The following is a description of a gene set: from publication Yevshin I, Sharipov R, Kolmykov S, Kondrakhin Y, Kolpakov F (PMID 30445619) Genes containing one or more binding sites for (Hnf4g) in their promoter regions (TSS -1000,+100 bp) as identified by GTRD version 20.06 ChIP-seq harmonization. Mouse Gene Set: HNF4G_TARGET_GENES species: Mus musculus, and this is the list of marker genes: Ggcx, 2610005L07Rik, A330032B11Rik, Slc35c2, Dnajc25, Prickle4, Acot4, Ccnyl1, Sardh, Cldn7, Socs2, Ambra1, Gm11696, Wapl, Mgam, 2010003K11Rik, Fv1, Tpi1, Btnl2, Slc25a5, Tkfc, Slc38a6, Kyat1, N4bp2, Ngef, Acot8 (NCBI Gene Id 170789), Gsdme, Sdc1, Dhcr7, Trappc9, Atp5mc3, Zfp956, Emp1, 1700018L02Rik (RIKEN cDNA 1700018L02 gene), Pak1ip1, Gm829, Acadm, Cnpy1, Gm9484, Cct4, Xkr5, Ylpm1, Fam47e, Tm4sf20, Tldc2, Pgrmc1, Naxd, Usp5, Tmcc3, Ubash3b, Arhgef16, Ddost, Scrn2, Crebzf (NCBI Gene Id 70721), H4c8, Hgfac, Add1, Tcf25 (NCBI Gene Id 72298), Eif5, Iyd, Spdye4b, Epha2, Atg4d, Slc1a4, Slc30a1 (solute carrier family 30 (zinc transporter), member 1), Cyp2s1, Ap1ar, Itsn1, Dnase1, Gm38250, Sesn1, Pigl, Nhsl3, Nisch, Cldn2, Eif4h, Zmat1, Odad3, Eaf2, Reno1, Mir7240 (NCBI Gene Id 102466823), Sec22c, Zbtb40, Mkln1, Ist1, Gm3948, Eef1b2, Atp6v0d1, Pde8b, Zyx, Mirlet7c-2, Mad2l2, 4930511M06Rik, Slc2a7 (solute carrier family 2 (facilitated glucose transporter), member 7), Cript, Vil1 (NCBI Gene Id 22349), Plscr2, Vcpip1, Cideb, Cxcl11, Ints10, Rgs3, Osr2, Gm11844, Ckmt2, Bach2, Trafd1, Map2k4, Bri3 (NCBI Gene Id 55950), Celsr3, Pyroxd1, Atp6v1a, Pank2, Tcn2, Nfyc, Ptpn3, Aftph, 1700021P04Rik (NCBI Gene Id 75521), Dpf2, Asah2, Pm20d1, Epg5, Trim7, Epn1, C230037L18Rik, Acsl1, Rcor3, Paxbp1, Sgk3, Patj, Cyp24a1, Smarcc1, Xpnpep2 (NCBI Gene Id 338497), Mitd1, Gipc2, Acp5, Pxylp1, H2-T5, Alkbh3, Arsg, Sel1l3, Foxk2, Sbf1, Efnb1, Il4ra, Zfp1, Rcc1, Rhpn1, Rbl1, Farp2, Alas1, Mep1b, Lrp4, Gramd1b, Cnst (consortin, connexin sorting protein), Sec16a, Pcmtd1, Abhd14a, Lif, Enox2, Nop58, Btnl5-ps, B930036N10Rik, Dnm1, Tcf3, Slc23a2, Tpcn1, Carhsp1, Trpm5, Fgf9, Gm15901, Hic2, Naa50, Ppp1r16a, Gm4755, Ccnl1, Pdzk1, Cyp4f14, Cramp1, Lmo7, C2, Gne, Gm15401, Cenpv, Dcdc5, Ifngr1, Mrpl33, Dusp12, Pafah2, Gltpd2, Gm7285, Sqor, Pms2 (NCBI Gene Id 18861), Gpsm2, Rock2, 2810405F17Rik, Pla2g2e, Hmgcs1, Pfkp, Inpp4a, Pabpc4, Cep57l1, Ogt, Polr2b, Aunip (NCBI Gene Id 69885), Sra1 (NCBI Gene Id 24068), Prag1, Tm6sf2 (transmembrane 6 superfamily member 2), Akt2, Bid, Alpi, Slc5a9, Pbld2, Arf4, Hdgfl2, Lctl, Mcm10, Gm16984, Elk4, Tob2, B230206L02Rik, Dglucy, Slfn2, Tyw5, Tpcn2, Ucp2, Bmp2k, Nt5c, Relch, Acot12, Ddr1, Eogt, Gm12188, Pex11g, Sepsecs, Gsk3a, Hdhd3, Gm15938 (NCBI Gene Id 105245873), Gm13588, Plekhs1, Tbcd, Erg28, Elf4, Nkap, Zhx2, Arrdc4, Pde11a, Gcc1, Ccs, Gm9945, Tmem236, Arl1, Gm15587, Sptlc1, Cacul1, Tom1l1, Eif1a, Cimap2, Sult1b1, Tmem147, Eif4b, Gm23054, Gm14050, Inafm1, Fam110c, Cfap61, Tbc1d1, Tnpo3, Bloc1s2, 1700001L05Rik, Prrx1, 2010010A06Rik, Ten1, Rps27l, Lgalsl, Sgpl1, Tap2 (transporter 2, ATP-binding cassette, sub-family B (MDR/TAP)), Rest, Ankrd9, Miip, Bmf, Kyat3, Cdhr5, Hycc1, Arcn1, Atp5f1b, Gnl2, Erich4, Nr2f6, Ift140, Tmem120a, Mrpl44, Cflar, 2310030G06Rik, Hpdl, Idua, Slc9a2, Adprm, Ccser2, Nqo2, Flacc1, Tnfaip8l2, Ldlrad3 (NCBI Gene Id 98873), Kmt2c, Irf1, 1810013D15Rik, Lmbrd1, 6030442K20Rik, Gm13963, Kif15, Irf2bp2, Dnajb11, Adcy3, Oser1, Nckap5, Irf9, Krtap3-1, 4930443O20Rik, Cttnbp2, Cct8, Traj57, Rnps1, Efna1, Dhrs1, Chd2, Pih1d1, Cpeb2, Gm4651, Herc3, Gm11457, Enpp7, Myl4, Ebpl, Cbl, Tsg101, Jade1, Itga9, Arhgef18, Ccdc50, Tmigd1, Arfgef1, Rprd1b, Dctn5, Eif3f, Ifnl3, Ankrd13c, Ap1m1, Eif2ak2 (NCBI Gene Id 76759), Slc6a8 (NCBI Gene Id 12911), Zfp36l2, Tlcd4, Slc26a6, Bcr, Wdcp, Ncoa4, Tmc6, Cerk (ceramide kinase), Ces2c, Slc51a, H2-Q4, 2200002D01Rik, Pls1, Slc5a8, Mir3079, Nfil3, Psma4, Agxt2, Nup54, Pkn2, Fbxo22, Parp11, Tmem150b, Map3k10, Mmp24, Tbcel, Mgat3, Cdc42ep5, Aars2, Gm8849, Ces2a, Ift46, Wfs1, Gm4925, Cyp3a11, Pigm (NCBI Gene Id 98637), Pinlyp, C8g, Slc3a1, Cdk5rap1, Maoa, Ube2f, Gnai2, Actr2, Or52h9, Cpd, Ank3, Ptpn6, Phf7, Litaf, Aloxe3, Mir378a, Prr3, Irgm2, Chrna2, Ski, Lpin3, Arhgap27 (Rho GTPase activating protein 27), Slc10a5, Slc5a12, Gdi2, Aimp1, Ggt6, Mlycd, Rusf1, Slc7a15, Tnfaip3, Cant1, D5Ertd579e (DNA segment, Chr 5, ERATO Doi 579, expressed), Zbtb33, Lrrc66, Tulp4, Igsf23 (immunoglobulin superfamily, member 23), Tfrc, Ap5s1, Gm22018, Mir8116, Tmem51, Acbd4, Seh1l, Dck, Ifi27l2b, Nr1h3 (NCBI Gene Id 99182), Tmem106a, G6pc1, Usp3 (ubiquitin specific peptidase 3), Ganc, Kcnj8, 2310057M21Rik, Snai3, Klhdc8b, Mir8106, Zfp865 (NCBI Gene Id 319748), Junos, Dcp1a, Abcb4, Treh, Mrpl40 (NCBI Gene Id 18100), Camk2d, Ogfod3, Ccnk (cyclin K), Rsbn1l, Gm25857, Neu2, Gm28035, Ttll5, Cth, Slc35b1, Mrpl32, Rxra, Cfap74, Ormdl1, Mab21l4, Hes6, Snrpc, Ces3b, Sgk1, Gramd2a, Gm8813, Ppp1r14d, Apob, Itpka, Fbp2, Dcst1, Smad7, Aspdh, Ints8, 5031439G07Rik (RIKEN cDNA 5031439G07 gene), Tmem143, Spink1, Crip1, Mep1a, 4833439L19Rik, Brd10, Btf3l4, Pcnx3, BC016579, Naga, Klf4, Angptl8, Cyp3a13, H2-T9, Mst1r, Tnk1, Fcho2, Pxn, Dop1b, Myo1a, Kbtbd11, Rdh5, Slc30a2, Specc1l, Cdkl1, Hnf1aos1, Sh3gl2, Taok3, Crat, 6530401F13Rik, Maf, Apoc2, Kdm6b, Rmi1, Gm11468, Tnfrsf1a, Grtp1, Stoml1, Adtrp, Ablim1, Chac2, Il11ra1, Rad9b, Snx20, Rps5, Tmem253, Mapk1ip1l, Rdh16f2, Rcbtb1, Rsrp1 (NCBI Gene Id 72409), Prpf4, Gtf3a, Ssbp2, Macir, Gm12915, Rapgef1, Arfip1, Prpf18, Ecd, Lims1, Ankrd37, Traj3, Fhip1b, Ino80c, Abhd16a, Kiss1, Cyp4b1, Rassf1, Cds2, Tmem86b, Kdm3a, Mkrn1, Gm22310, Gm4285, Kmt5a, Elovl6, Tpd52, Sf1, Vcpkmt, Cnksr1, Zfp706, Slc7a7, Rhobtb1, Foxp1, Apba3, Srsf2, Abhd14b, Frrs1, Zfp110, H2-Q1, Uso1, Mpz, Babam2 (NCBI Gene Id 77716), Mtbp, Ndufab1, Ptbp3, Stx16 (NCBI Gene Id 99409), D630024D03Rik, Mir5615-2, Ifi27, B230354K17Rik, Jak1, 1810008I18Rik, Sertad2, Dtx4, Txndc12, Bok, Mrpl1, Pou6f1, Akap10, Ubap2l, Ptpmt1, Dgkq, Nudt19, Cd160, Itih5, Mfn1, 4833420G17Rik, Gnl1, Rbm48, Gm16982, Fhl2, Cyp2b10, Igtp, A230107N01Rik, Ndufs6, Spen, Selenop, Mtarc2, Pik3r2, Rab11b, Gm16191, Cyp2c65, Mtrf1l, Tjap1, 9330175E14Rik, Fuom, Cenpa, Ggn, Gm12610, Rnasel, 1810019D21Rik, Rbm4b, Gm16096, Crybg2, Chchd7, Myo7a, Dnaaf5, Nek2, Cdk16, Rbm47, Hyal2, Nosip, Rwdd2b, Sf3a2, Cdc26, Aen, Chd1, Mical2, Vps26c, Gm17135, 4933434E20Rik, Gm22847, Snap23, Pstpip2, Bend7, Pklr, Mov10, Lrrc8b, Timm13, Rpl22, Mrpl35 (mitochondrial ribosomal protein L35), Acat3, Chp1, Chst8, Nrap (NCBI Gene Id 18175), Ttc27, Ptpre, 4930442L01Rik, Sgms1, Zfp93, A230083G16Rik, Rbak, Otulin, 1110059G10Rik, Synpo2l, Aqp1, Ciapin1, Mkks, Rab11a, Med6, Lyz1, Irak2, Ppdpf, Smu1, 6030445D17Rik, D2hgdh, Dnajc24, Mme, Mir1934, Ube3a, Traj56, Sema6a, Decr1, Rgs12 (NCBI Gene Id 77052), Pmf1, Slc2a5, Mafg, Nudt12, Rnf7, Entpd8, Tmem38a, Ctnna1, Myrfl, Mapre2, Tprn, Sult2b1 (NCBI Gene Id 545963), Cers6, Sdhc, Syne2, Prap1, Atp6v1e1 (NCBI Gene Id 76771), Pstk, Lpar1, Maip1, Nadsyn1, Pttg1ip, Gins3, Gm10244, Ubqln1, Resf1, Ankrd40cl, Rnf128, Erc1, Pgm1, Ppt2, Sec16b, Gm12220, Tiprl, Spata13, Mtarc1, Ece1, Copa, Zfp69, Il13ra1, Lztr1, Foxk1, Dclre1a, Cep170b, 4632415L05Rik, Ccdc57, Slc25a25, Nek3, Tgfbi, Slc36a1, Cers2, Spats2l, Gm11586 (NCBI Gene Id 105243487), Gm35066, Lpcat3, Wasf2, Ccdc87, Cd81, Fut7, Wdr44, Gapvd1, Syngr4, Prrg2, Abcg5, Nbeal2, Plin2, Rpl7, Ppme1, H2-K2, Gmip, Tmem177, Zfpm1, Gin1, Inpp5a, Mir6909, Pou2af2, Ulk2, Ganab, Gata4, Cpsf1, Fmn1, Imp3 (IMP3, U3 small nucleolar ribonucleoprotein), Slc2a9, Gm23664, Top1, Golt1a, 2310016D23Rik, Snx1, Lrrc27, Guca2b, Fgd6, Fcsk, B130034C11Rik, Mapk8, Prpf40a, Ltbr, Bcat2, Setd3, Edf1, Frs3, H2-Q3, Hus1, Ctns, Cd9, Hdac11, Nostrin, Tti1 (NCBI Gene Id 98972), Gucd1, Pcnx1, Rad51, Rassf7, Med16, Cenpu, Zc3h6 (NCBI Gene Id 99301), Rogdi (rogdi homolog), Arl6ip6, Tbc1d14, Nr1i2, Cisd3, Cdc37l1, Gm11545, H2-Q2, Rasl2-9, Rbbp5, Lman1, Wdfy1, Trmt5, Ercc6, Unc93a2, Proc, Ppp1r18, Mtmr7, Mir203, Net1, Gm13250, 4933433G15Rik, Hadh, Neurl2, Uap1l1, Plscr3, Abat, Golim4, Gabarapl1, Rbks, Ube2i, Pkp4, Anxa4, Pabpn1, A1cf, Cab39, Mir7036b, Slc35a4, Slc41a2, Arsa, Gm13203, Aldh9a1, Phf10, Ran, Ilrun, Acy1, Alg14, Rab20, Washc4, Etfbkmt, Ihh, Akr1c14, Ccdc126, Dsg2, Gm42918, Cyp4f16 (NCBI Gene Id 70101), Xdh, Trp53rkb, Cox16, Gtf3c2, Strap, Rab43, Flot1, Rmdn3, Arhgef26, Clrn3, Sco1, Acox2, Mtmr4, Gba2, N4bp2l2, Gm14441, Stxbp2, Gm12602, Qars1, Gstm3, Rras2, Gm14167, Atat1, Pigg, Taco1, Rffl, Brip1os, Tbccd1, Tdrd3, Sf3b6, Ggnbp2, Slc47a1, Mir6349, Ino80, 2610021A01Rik, Gchfr, Gpt, Rars2, Strn, Susd2, Plpp1, Slc6a19, Mycbp2, 2900093K20Rik, Lamtor2, Fam3b, Smt3h2-ps2, Esrp2, Aoc1, Gm38388 (NCBI Gene Id 105243936), Slc43a2, Hectd2, Atp6v0a1, Nags, Ampd2, Cyp2c55, Ppp1r18os, Ptprh (NCBI Gene Id 545902), Tchp, Ctsa, Amn, Epb42, Spred3, Ndufaf4, Glyctk, Zdhhc12, Xrcc1, Stx3, Tmem87a, Hcn1, Ap2b1, Susd3, Sucla2, Slc25a14 (solute carrier family 25 (mitochondrial carrier, brain), member 14), Dgcr6, Mrpl34, Dnajc22, Rpl15, Rnf11, Gm5656, Wee1, Pafah1b3, Tmem37, Mapkapk2, Gm20619, Oga, G630022F23Rik, Rnd2, Brpf3, Ptbp1, Dtx3l, Tkt, Mpzl2, Mapk9, Cdk5, Ttk, Tg, Tnfsf10, Cox7a1, Gtf2e1, Stub1, Rmnd1, Rad54b, Zfp784, Hectd1, Pold2, Paip2 (NCBI Gene Id 67869), Tpt1, Ptprd, Adap1, Gnpda1, Pdia5, Bco1, Slain2, Uqcc6, Mir1932, Hmgcr, Tmc4, Cd47, Ttc33, Gm10658, Slc5a11, Elmo2, Raf1, H2-T15, Mettl27, Plekhj1 (pleckstrin homology domain containing, family J member 1), Bsdc1, 4933404O12Rik, Spg7, Zbtb7b, Lgals4, Atg5, Palb2, Gimd1, E030042O20Rik, Spaca7b, Tmem184a, Btf3, 9130019P16Rik, Gm11945, Adgrg7 (NCBI Gene Id 239853), Amfr, Bms1, F3, Gpr107, Gadd45a, Mfsd4b3-ps, Lgals2, Scpep1, Dmac1, Bst1, Rarg, Anp32a, Timm17a, Crnkl1, Gpa33, Gstm4, Dnaja2, Card14, Abhd15, Zfp872, Il17rb, Trim28, Cdc5l, Ice2, Zfp112, Pts, Alkbh7, Rps3a1, Mesd, Med27, Ifih1, Rab30, Hpgd, Rbm34, Vapa, Glt28d2, Sgpp2, Kmo, Mcfd2, Midn, Gm11527, Mlxipl (MLX interacting protein-like), Slc5a4b, Fryl, Cand1, Dgat1, Zbtb11os1, Leng9, Phgr1, Dao, Efcab7, Sec61a2, Slc16a3, Pnrc2, Ube4a, AY074887 (NCBI Gene Id 246735), Gm4189, Plag1, Zfp830, Mdh1b, Nop9, Mettl17, Tmc5, Ms4a10, Ssu72, Rnf121, Mycbpap, Ccdc97, Dlat, Gm12500, Tapbp, Spns2 (NCBI Gene Id 216892), Unc93a, Ecpas, Polr2a, Mir194-2, Fdxr, Wdtc1, Aldh16a1, Gm9409, Crb3, Fmo4, Apoc3, Src, Npas2, Commd2, Tmem165, Mttp, Has2os, Gm14383, Sun3, Nuf2 (NCBI Gene Id 98608), Gde1, Neurl4, Rab40b, Mir3968, Cntn2, Capn8, Tepsin, Cox19, 4632427E13Rik, Baiap2l2, Slc5a6, Gm7854, Doc2g, Sec24a, Gm14966, Nfe2l2, Furin, Clec2e, Pex11b (peroxisomal biogenesis factor 11 beta), Birc3, Otc, Mir429, Hdac4, Itgb5 (integrin beta 5), 2310005A03Rik, Man2b2, Abr, Rcc1l, Pex1, Gramd1c, Clcc1, Btbd2, Cast, Gm11335, Mdh1, Ndel1, Mtfr1l, Itgb4, Rab17, Alg11, Fbxw9 (NCBI Gene Id 68628), Wdr11, Ccdc71, Cfb, Dnajc28, Prkca, Hnrnpc, Taco1os, Cdcp1, Nyap1, Cyb561d2, 4833407H14Rik, Brip1, Cd302, Il22ra1, Asic3, Slc18b1, Slc5a1, 9130230L23Rik (NCBI Gene Id 231253), Bmal1, Erbb2, Slc16a1, Oma1, Rbm15, Ik (IK cytokine, NCBI Gene Id 24010), Golgb1, Gapdh, Ifit3b, Eif4g1, Mrps18b, Nat8f2, Tmbim6, Ralgds, Emc9, Rgp1, Abcd3, Tnnt1, Cct6b, Txn2, Tmem82, Nos1ap, Cct3, Mia2, Bnip3, Armt1, Smim15, 9430060I03Rik, Abcc3, Mir192, Rdh7, Carm1, Cit (citron), Pold3, Mfsd11, Ppie, Scp2, Ddit3, Selenoi (selenoprotein I), B3gnt2, Mgst2, 2810408A11Rik, Chdh, Otud7b, Cdhr2, Clec2h, Edn3, Azin1, Wipf3, Zfp354a, Ttn, Btnl6, Dkk4, Rasl10b, Tcf12, Dcaf10, Prkar1b, Hnf1a, Nlrc4, Podn, Eci3, Smarcd2, Nr1i3, Psma2, Senp1, Tuft1, Hes1, Eva1c, Zkscan1, Gm5475 (predicted gene 5475), Zfp696, Vps26a, Megf11, Itpripl2, Slc4a2 (NCBI Gene Id 20535), Fas, Upp1, Plec, Cspg4, Apbb1, 9930014A18Rik, Stx4a, Rdh9, Fastkd2, Ncor1, Mkln1os, Herpud1, Cpox, Ggt1, Gm42814, Anks4b, Ppp1r10, Prss30, Tmem238l, Stxbp6, Myo15b (myosin XVB), Hnf1b, Ptpa, Ctcflos, Rnf103, Osbpl6, Tcf7, Bpnt1, Fam107b, Prxl2a, Gm12059, Gm21049, 2610528J11Rik, Mtmr11, Smim7, Nrxn2 (neurexin II), Ppp4r3a, Grb7, Nckap1, Brwd1, Dennd6a (NCBI Gene Id 211922), Baat, Entpd5 (ectonucleoside triphosphate diphosphohydrolase 5), B3gnt3, Gpr35, Pdgfc, Chmp6, Slc28a1, Ms4a8a, Hacd2, Dnajc13, 2010308F09Rik, Stk24, Tmc8, 4930562C15Rik, Tjp1, Hivep1, Selenbp1, Tap1, Gm19391, Ptms, Slc9a3, Gm4349, Nfia, Pax6 (paired box 6), Qdpr, Cdc27, 4931413K12Rik, Eef2, Cyp27a1, Casz1, Gm17089, Tuba1c, Snora24, Gm13580, Cul4a, Gal3st1, Gas2, Cry2, AI507597, Abhd2, Gm11451, Slc35a3, Mrpl30, Psmd3, Mtif2, Lysmd4, Bud13 (NCBI Gene Id 215051), Chka, Isx, Cyb561, Fos, Pag1, Snhg8, Gzf1, Ppif, Fkbp1a, Slx4ip, Gas2l1, Spmip4, Islr2, Atpaf2, Gm15889, Sde2, Zbtb7a, Gsn, Arc, Ifnar1, Nabp2, Ctso, Myo7b, Perp, Slco2a1, Cyp2c29, Odad1, Pms1, Fam98c, Ube2c, Trmt61b, Trabd2b, BC004004, Bcl2l15, Nr1d2, Zfp948, Lrp3, Fbxw5, Fam53b, Nherf4, Fam169b, Csnk1d, 5730480H06Rik, Baz2a, Ceacam18, Ppp5c, Bco2, Gm15941, Gm10010, Zcchc8, Sec14l1, Tcerg1, Creb3l2, Prkcsh, Zfp292, Eps15, Orc3, Chmp2b, Hspa13, Gm29609, Pxdc1, C2cd3, Mpdu1, Gtpbp8, Nprl2, Proz, Sphk1, Mapk6, Zfp607b, Coro1c, Serpine1, Sectm1b, Tm4sf5, Spata1, Slc5a4a, Plscr1l1, Gm15417, Acad9, Nme9, A830005F24Rik, Abhd1, Ncaph2, Gga1, Dcxr, Rbp2, Park7, Hexim2, B4galnt2, Preb, Sema4a, C1rl, Sin3a, Zfp827, Cep89, Itga1, Eny2, Smim27, Plk5, Lypla1, Rad54l2, Oxr1, Fgd4, Cblc (NCBI Gene Id 80794), Zfp92, Scmh1, Gm26397, Rragc, Mroh7, Dsc2, Saxo2, Agrn, Nedd1, Efhd1, Gm4929, Mir1936 (NCBI Gene Id 100316812), Msh3, Arb2a, Ankrd54, 5430435K18Rik, Nup133, Tmem101, Espn, Ctif, Atg2a, 1700084C06Rik, Ap3m1, 4931406C07Rik, Cldn15, Sp1, Hsd17b13, Matr3-ps2, Pdcd11, Aqp8 (aquaporin 8), Aldh3b1, Mir7214, Blmh, Kalrn, Plekha7, Tmem139, Cldn3 (NCBI Gene Id 12739), Gm9917, Gm11544, Gp6, Nmi, Khdrbs1, Zfp286os (zinc finger protein 286, opposite strand), Mob3c, Ap1g1, Hook2, Tmem117, Lpp, Borcs6, Mllt11 (myeloid/lymphoid or mixed-lineage leukemia; translocated to, 11), Mir3103, Gng5, Rufy1, Traj4, 5330413P13Rik, Dusp23, Naprt, Tec, Trmt44, Gm14097, Pck1, Txndc15, F830112A20Rik, Gpatch4, Ugdh, Iqcd, Icmt, Sipa1l3, Misp, Ak2, Morn2 (NCBI Gene Id 378462), Ces1e, Gcfc2, Dock7, Tmbim1, Ddhd1, Whamm, Gcnt4, Ndufs1, Slc25a3, Gm26761, Acyp1, Acat2, E230016M11Rik, Arpin, Cgref1, Tnrc18, Akr1b7, Cdca3, Gm22591, Itgb3bp, 4933427D14Rik, Hadha, Gm42458, Krt20, Plekhg6, Gm19620, Arid1a, Dctn4 (dynactin 4), Chp2 (NCBI Gene Id 70261), Lgals3bp (lectin, galactoside-binding, soluble, 3 binding protein), Fancf, Mospd3, Acap2 (ArfGAP with coiled-coil, ankyrin repeat and PH domains 2), Abcc6, Vps51, Inava, Vav3, Gtpbp2, Tmt1b, Dnaaf4, B4galt4, Mtpap, Tsr1, Gcc2, Asah1, Gm15908, Slc12a7, Sgms1os1 (Sgms1 opposite strand transcript 1), 2010106E10Rik, Abcg8, Nap1l4, Pus10, Kif11, Itpripl1, Gcat, 2810030D12Rik, Etfa, Atp7b, D330041H03Rik, Top2b, Dnm2, Myo18a (NCBI Gene Id 360013), As3mt, Dedd, Atp13a1, Ift20, P3h4, 4930539J05Rik, Exd1, Aqp3, Mrpl13, Dab2ip, Rdh10, Rrp36, Hid1